Given this list of marker genes SLC1A3, RAB11B, AP4E1, ASXL1, ATP1A3, PURA, AMPD2, DMPK, POGZ, POU3F3, YY1, KDM5C, NGLY1, PAX7, VPS13B, HERC1, GPC4, STAG2, ZBTB11, PPP2R1A, PCGF2, SATB2, CACNA1A, RNU4-2, PPP2R5D, KDM4B, XYLT2, DSE, CAMK2G, ATP1A2, DYNC1H1, AP4B1, AP4S1, AP4M1, STRADA, GPC3, SLC30A9, KCNK4, ZMIZ1, TET3, CHAMP1, MECP2, MYOT, SRRM2, GRIA3, MAN2B1, UNC80, GAA, SET, here is a description of the gene set: Reduced muscle tone of a muscle that is innervated by the facial nerve (the seventh cranial nerve). Facial hypotonia species: Homo sapiens Human Gene Set: HP_FACIAL_HYPOTONIA